The following is a description of a gene set: Human Gene Set: MIR6740_3P from publication Chen Y, Wang X (PMID 31504780) studied in species Homo sapiens Genes predicted to be targets of miRBase v22 microRNA hsa-miR-6740-3p in miRDB v6.0 with MirTarget v4 prediction scores > 80 (high confidence targets)., and this is the list of marker genes: STK35, TLL1, ETNK1, VCL, NBPF14, ULBP3, CNOT7, ZNF275, SLC30A4, DOCK4, ANKRD7, ELAPOR2, EIF4A1, CHCHD3, YTHDC1, SPAST (spastin), MRPL36, SPRY4, ACVR2A, INPP5K, ARK2N, PAPPA, NDFIP2, FGF14, TMEFF1, RHOJ, CEP15, PRRC1, PIF1, KDM5D, FOXJ3, LVRN (laeverin), S1PR3, DUSP3, EPHA7, TTBK2, TMEM38B, HLCS, SBK1, PTPN12, USH2A, RAPGEF2, NODAL, HSBP1, SYNPR, LPP, P2RY14, ESCO1 (establishment of sister chromatid cohesion N-acetyltransferase 1), DNAJC27, PRKAB1, COPS4 (NCBI Gene Id 95620), PHACTR2, TTPAL, DUSP11, ANKRD50, ZSCAN30, DENR, NONO (non-POU domain containing octamer binding), TRABD2B, KIF3B, ATP7A, PDPN, SLC13A4, SMCO3, PFDN4, GPATCH2L, INPP4A, HUS1, ACAA2, ZBTB18, CMPK2, PSG1, DNAL1, XYLB, TAF4B, ZNF75A, FCRL4, SUPT3H, DDHD1, FASLG, KLF5, TMEM212, LRRTM3, HNRNPA1, MACO1, ARID1A, TMEM39A, PDE4DIP, CCT2, CD9, NRXN1, HNRNPA1L2 (heterogeneous nuclear ribonucleoprotein A1 like 2), TINF2 (NCBI Gene Id 26277), AAK1 (NCBI Gene Id 652453), GZMK, RBPJ, PTCHD3, FAM9C, PURA, UBE3A, IFRD2, SEMA6D, HEATR5A, CHN2 (NCBI Gene Id 644086), ADAM12, SRSF10, C10orf62, GATAD2B, TECTB, TYW3, ZNF704, BTBD3, POLR3E, WDR17, NBEA, MANEAL, LDAH, DERL2, KCMF1, SESTD1, MSANTD3-TMEFF1, MEGF11, FAM9B, SALL1, STAT1, SH2D4B, TC2N, AIG1, KDM2B, GPR6, MARCHF6, XRCC2, LRRC18, BRINP3 (BMP/retinoic acid inducible neural specific 3), ATP2B1, MEGF10, FGF18, PPP4R2, SLC25A36, ZNF70 (NCBI Gene Id 7621), ACTN4 (NCBI Gene Id 81), GYPA, RASSF8, AXIN2, SIK2, MORN4, GALNT13, HTR4, SHTN1, GLI2, TCTN1, EBAG9, DUSP1, TNPO3, CHRM5, RALGAPB, CDR1, KCNA1, HOXA4, ZNF462, C1orf226